The following is a description of a gene set: Catalysis of the reaction: NADP+ + trans-1,2-dihydrobenzene-1,2-diol = NADPH + catechol. studied in species Mus musculus Mouse Gene Set: GOMF_TRANS_1_2_DIHYDROBENZENE_1_2_DIOL_DEHYDROGENASE_ACTIVITY, and this is the list of marker genes: Akr1cl, Akr1c21, Dhdh, Akr1c6, Akr1c20, Akr1c14